The following is a description of a gene set: Catalysis of the transfer of a phosphate group to a histone. Mouse Gene Set: GOMF_HISTONE_KINASE_ACTIVITY studied in species Mus musculus, and this is the list of marker genes: Mknk1, Ern1, Lmtk3, Cask, Srpk3, Lmtk2, Tssk1, Csnk2a1, Nek2, Akt1, Srpk1, Pik3ca, Csnk1g1, Taok1, Mark1, Aurkc, Map4k3, Taf1, Bub1, Csnk1a1, Dclk3, Rps6ka3 (ribosomal protein S6 kinase polypeptide 3), Stk3, Nek9 (NCBI Gene Id 353030), Pik3cg, Map4k1, Stk35, Tnk2, Map3k7, Prkcb, Stk25, Wnk2, Mast4, Stk24, Trp53rkb, Tlk2, Eif2ak2, Mastl, Map3k19, Csnk1g2, Dapk1, Wnk3, Trpm7, Stk32b, Mos, Brsk2, Cdk5, 4921509C19Rik, Rps6kb1, Braf, Obscn, Sik2, Rps6kl1, Smok2b, Slk, Csnk2a2, Dcaf1, Nek8, Aatk (NCBI Gene Id 11302), Oxsr1, Ripk3, Prkdc, Map4k2, Sgk2, Tnni3k, Prkaa1, Mapkapk3, Phkg1, Alpk1, Hipk1, Stk17b, Sik3, Mink1, Aurka, Srpk2, Rock1, Rps6ka2, Csnk1g3, Rps6ka5, Nrk, Pim2, Stk10, Pkn1, Bmp2k, Prpf4b, Ksr1, Pskh1, Stk33, Pak4, Map4k5, Chek2, Irak4, Tnik, Mapkapk2, Ulk1, Alpk2, Pak6, Ulk2, Pak5, Pak2, Uhmk1, Cdk2, Raf1, Eif2ak3, Rock2, Cdc42bpa, Ttbk1, Smok2a, Mast3, Rps6kc1, Ksr2, Gm4922, Rps6ka6, Atm, Stk26, Mapkapk5, Eif2ak4, Ern2, Speg, Bub1b, Rskr, Baz1b, Hunk, Ripk1, Pak3, Map4k4, Sgk3, Trpm6, Stk16, Mtor, Tbk1, Nim1k, Csnk1d, Stk36, Kalrn, Haspin, Rps6ka4, Dclk2, Ripk4, Tssk5, Sbk2, Aak1, Chek1, Melk, Trio, Wnk4, Pask, Stk-ps2, Sgk1, Irak1 (interleukin-1 receptor-associated kinase 1), Dyrk1a, Araf, Bcr (BCR activator of RhoGEF and GTPase), Ttn, Smg1, Stk31, Tssk3, Smok3a, Mast2, Riok1, Limk2 (NCBI Gene Id 97744), Nek11, Prkca, Cdc42bpb, Akt3, Mark2, Nuak2, Csnk1e, Cdk1, Hipk2, Pkmyt1, Prkx, Stk40, Vrk2, Stk38, Pink1, Akt2, Nek5, Stk32c, Riok2, Ulk4, Nek7, Aurkb, Pak1, Atr, Stk11, Cdc42bpg, Rps6ka1, Nuak1, Brsk1, Stk38l, Pdik1l (PDLIM1 interacting kinase 1 like), Prkaa2, Pikfyve, Ankk1, Pim1, Lrrk1, Eif2ak1, Pdpk1, Alpk3, Mark4, Pkm, Tssk6 (NCBI Gene Id 83984), Myo3b, Taok2, Ciita, Mast1, Ikbkb, Myo3a, Stk32a, Dmpk, Dapk2, Fam20c, Taok3 (TAO kinase 3, NCBI Gene Id 72857), Cilk1, Snrk, Smok3b, Tlk1, Hipk4, Jak2, Lats1, Hipk3, Tssk4, Limk1, Nek6, Gsk3b, Ttbk2, Gm7168, Gak, Gsk3a, Mknk2, Ulk3, Mst1, Wnk1, Sbk3, Stk4, Pim3, Mark3, Nek3, Mak, Pik3r4, Lrrk2, Sik1, Sbk1, Rps6kb2, Nek1, Nek4, Lats2, Cit, Cdc7, Stk39, Nek10, Mylk4, Tssk2, Dapk3, Riok3, Ripk2, Vrk1, Dclk1